The following is a description of a gene set: A macromolecular complex containing separate protein and lipid molecules. Separate in this context means not covalently bound to each other. Mouse Gene Set: GOCC_PROTEIN_LIPID_COMPLEX studied in species Mus musculus, and this is the list of marker genes: Apof, Apoa2, App, Hp, Clu, Pla2g7, Selenos, Apoa4, Apol8, Apoa1, Apoc4, Apoa5, Saa3, Apol10b, Lpl, Gpld1, Lsr, Lipc, Pcyox1, Apoh, Apol9a, Apoc1, Bin1, Pon1, Apob, Msr1, Apoc3, Apobr, Apoe, Pex3 (peroxisomal biogenesis factor 3), Apom, Apol11a, Apol11b, Apoc2, Saa1, Apol9b, Pltp, Lcat, Apoc2l, Saa2 (serum amyloid A 2), Apol10a, Hdlbp, Dbi, Ldlr, Vldlr